Given this list of marker genes Ifi209, Sirt2, Cptp, Csnk1a1, Ifi207, Nlrc3, Lamp2, Ifi208, Irgm2, Trim11, Hspa8, Igtp, Ifi213, Mndal, Ifi203-ps, Ifi206, Trim31, Ogt, Ifi203, Trem2, Trim30a, Irgm1, Ifi214, Mefv, Abhd17a, Fbxl2, Zdhhc12, here is a description of the gene set: Any process that stops, prevents or reduces the frequency, rate or extent of an inflammasome-mediated signaling pathway. Mouse Gene Set: GOBP_NEGATIVE_REGULATION_OF_INFLAMMASOME_MEDIATED_SIGNALING_PATHWAY species: Mus musculus